The following is a description of a gene set: Toll-like Receptor Cascades Mouse Gene Set: REACTOME_TOLL_LIKE_RECEPTOR_CASCADES species: Mus musculus, and this is the list of marker genes: Peli3, Ppp2r1b (NCBI Gene Id 73699), Map2k4, Traf6, Ppp2r1a, Pik3r4, Optn, Ikbkg, Irf3, Rps6ka5, App, Ripk1, Irak2, Apob, Peli1, Ube2n, Ly96, Ppp2ca, Map3k7, Sftpa1, Fadd, Tirap, S100a1, Atf1, Creb1, Gsdmd, Mapk10, S100a8, Mapkapk3, Tlr4, Atf2, Ctsl (NCBI Gene Id 320361), Map2k3, Ticam2, Nfkbia (NCBI Gene Id 18035), Tbk1, Gsdme, Traf3, Itgb2, Ube2d1, Irf5, Fgb, Dnm2 (NCBI Gene Id 13430), Ecsit, Ly86, Ticam1, Tab1, Irf7, Uba52, Tnip2, S100a9, Slc15a4, Birc2, Unc93b1 (unc-93 homolog B1, TLR signaling regulator), N4bp1, Ripk2, Casp8, Tasl, S100b, Tab2, Rps6ka2, Ube2d3, Ube2v1, Map2k7, Eea1 (early endosome antigen 1), Nfkb1, Hmgb1, Irak1, Mapkapk2, Lgmn, Tab3, Usp18, Fga, Ubc (NCBI Gene Id 77003), Ppp2cb, Birc3, Tlr2, Uba52rt, Tlr6, Tank (TRAF family member-associated Nf-kappa B activator), Traf2, Rps6ka1, Ripk3, Sftpd, Lbp (NCBI Gene Id 16803), Nlrc5, Cd14, Cd180, Ptpn4, Itgam, Rbsn, Mapk14, Dusp7, Lrrc14, Ikbkb, Fbxw11, Rps6ka3, Tlr8, Vrk3, Tlr9, Chuk, Nkiras1, Plcg2, Fos, Ctsk, Dnm1, Tlr7, Cd36, Nfkbib, Ikbke, Usp14, Mapk11, Alpk1, Map2k6, Mapk9, Pik3c3, Nfkb2, Ptpn11, Mapk1, Dnm3, Jun, Ube2d2a, Hsp90b1, Dusp4, Ctsb, Mapk3, Tifa, Ppp2r5d, Nlrx1, Nkiras2, Rps27a, Map3k8, Skp1, Mapk8, Nod2, Fgg (NCBI Gene Id 99571), Ager, Sarm1, Ctss, Cul1, Dusp6, Ubb, Tlr1, Dusp3, Bpi, Mapk7, BC051665, Cnpy3 (NCBI Gene Id 73685), Peli2, Nod1, Rela